The following is a description of a gene set: Nephron development species: Homo sapiens Human Gene Set: REACTOME_NEPHRON_DEVELOPMENT, and this is the list of marker genes: LHX1, IRX2, WNT4, DLL1, PAX2, HNF1B, IRX1, POU3F3, WNT9B, JAG1, LFNG, HNF4A, WT1